Given this list of marker genes KLHL22, KLHL21, TUBGCP3, CUL3, TUBG1, here is a description of the gene set: studied in species Homo sapiens Any of the spindle microtubules that come from each pole and overlap at the spindle midzone. This interdigitating structure consisting of antiparallel microtubules is responsible for pushing the poles of the spindle apart. Human Gene Set: GOCC_POLAR_MICROTUBULE